Given this list of marker genes LINC03047, ITGA8, IGHM, KRTCAP2, CTHRC1, SLAMF7, SPATS2, PLA2G2D, IGHG4, LINC01480, IGLV6-57, UBE2J1 (ubiquitin conjugating enzyme E2 J1), TXNDC11, ENSG00000227619, JCHAIN, BRSK1, MANF, DNAAF1, PLAAT2, TGFBR3L, PARM1 (prostate androgen-regulated mucin-like protein 1), IGKV1D-8, TNFRSF17, LMF1, KDELR1, LMTK3, DNAJB9, IGLV3-21, TXNDC5, RABAC1, FCRL5, PDIA6, IGHA1, CHPF, BHLHE41, IGF1, SPACA3, SELENOS, MYDGF, IGHG3, PERP, LINC03034, SDC1, SSR4 (NCBI Gene Id 6748), IL5RA, CADPS2, IGKC, IGKV4-1, TXNDC15, LINC00582 (NCBI Gene Id 100293734), DTNB-AS1, MEI1, PRSS16, IGKV3-20, IGHA2, IGHG1, NXPE4, ERLEC1, CLDN3, IGLV1-44, IGLC3, IGKV1-39, IGLV5-48, XBP1, IGLC2, IGKV1-5, LMAN1, HSP90B1, HDLBP, TUBB2B, CCR10, WNT10A, SPCS2, FKBP2 (FKBP prolyl isomerase 2), MZB1, DERL3, LMAN2, IGHV3-7, IGKV3D-15, LINC02851, IGLL5, SDF2L1, LYPD6B, PDIA4, ARX, GPRC5D, IGHGP, SEC11C, ELL2, FKBP11, DPEP1, CRELD2, KCNMA1, MIXL1, MYL2, SPCS3, IGHG2, IGHV3-23, KCNN3, PIK3CD-AS2 (NCBI Gene Id 101929074), MOXD1, CST6, SSR3, RASGRP3, HERPUD1, PRDX4, CADM1, IGKV1-12, TMED9, JSRP1, KDELR3, MANEA, ARSA, IGLV1-51, CIBAR2, UGT2B17, ABCB9, GMPPB, FRGCA, IGHD, HID1, LINC02362, CLDN14, AMPD1, SPAG4, IGKV3-15, SCNN1B, IGLV2-14, HM13, ENSG00000253796, PAIP2B, KDELR2, ANKRD28, here is a description of the gene set: Human Gene Set: HAY_BONE_MARROW_PLASMA_CELL species: Homo sapiens from publication Hay SB, Ferchen K, Chetal K, Grimes HL, Salomonis N (PMID 30243574)